Given this list of marker genes DNA2, SLX1A, FEN1, ENDOV, EXO1, MGME1, DICER1, DNASE1L1, DNASE1, DNASE1L2 (deoxyribonuclease 1 like 2), GEN1, SLX1B, DNASE1L3, APEX1, FAN1 (NCBI Gene Id 22909), here is a description of the gene set: Catalysis of the hydrolysis of ester linkages within deoxyribonucleic acids by creating internal breaks to yield 5'-phosphomonoesters. Human Gene Set: GOMF_DNA_ENDONUCLEASE_ACTIVITY_PRODUCING_5_PHOSPHOMONOESTERS species: Homo sapiens